Given this list of marker genes Mlh1, Chmp5, Kmt5c, Gm773, Nsmce3, Gm10230, Cenpa, Hspa2, Aurka, Tex14, Xlr4c, Mtbp, Brd7, Nifk, Macroh2a1, Tuba1a, Ccnb1-ps, Gm21865, Zwint, Syce2, Aurkc, Aurkb, Brca2, Ago3, Ccnb1, Psen1, H3f3c, Nup160, Chek1, Gm2012, Rassf2, Rnf212, Dctn2 (NCBI Gene Id 97666), Smc1b (structural maintenance of chromosomes 1B), Chmp7 (charged multivesicular body protein 7), Ahctf1, Actl6b, Nup85, Birc5, Smarcc2, Ppp1r12a, Gm21117, Gm28870, Spdl1, Cenpt, Mki67, Top2a, Dynlt3, Ncaph2, Xpo1, 1700013H16Rik, Csnk1a1, Chmp3, Cenpw, Nsmce1, Smc5, Cfdp1, Phf2, H3f5, Ttn, Hormad1, H2ax, Polb, Xlr5b, Dync1i1, Gm28102, Smc4, Phf10, Septin2, Smarcd1, Actl6a, Crebbp, Sycp2, Sycp1, Gm1140, Dync1li2, Rrs1, Pinx1, Ska2, Gm29866, Nup107, Dctn1, Kntc1, Dctn3, Cenph, Clasp1, Gm28576, Champ1, Arid2 (AT-rich interaction domain 2), Syce1, Trp53bp1, Sycp3, Smarcd2, Rad50, Sgo2b, Gm21760, Dctn5, Gm20824, Ncapd3 (NCBI Gene Id 78658), Bub1, Chmp6, Mei4, Gm5934, Septin6, Pbrm1, Sugt1, Msh5, Cebpb (NCBI Gene Id 18031), Cenpk, Chmp2a, Cenpi, Fbxo28, Lrwd1, Setmar, Cenpn, Ckap5, Rad9a, Rnf212b, Top3b, Clasp2, Zfp207, Kmt5b, Bub1b, Zw10, Cenpx, Nudcd2, Apc, Gm20890, Cdx2, Nanog, Gm29554, Ska1, Gm20911, Xlr3a, Chmp1b2, Zfp276, Chmp4c, Sec13, Meaf6, Hsf1, Fancd2, Nscme3l, Ndc80, Rad9b, Rad51, Xlr3c, Rsph1, Ska3, Cenpc1, Cenpe (centromere protein E), Gm21627, Esrrb, Cdt1 (NCBI Gene Id 97441), Lig3, Pafah1b1, Nsl1, Ttk (Ttk protein kinase), Hormad2, Syn1, Rad21 (NCBI Gene Id 19357), Nol6, Smarca4 (NCBI Gene Id 20586), Ncapg (NCBI Gene Id 70636), Psen2, Hmbs, Gm20817, Mre11a, Cenpv, Gm20820, Knstrn, Fbxw11, Trappc12, Zwilch, Sun2, Brd4, Nde1, Chmp4b, Prpf4b, Atf6b, Nup98, Actb, Banf1 (NCBI Gene Id 98145), Cenpb, Kansl1, Kif2c, Ercc6l, Spc25, Cenpf, Spag5, Dynll1, Cbx5, Kifap3, Ctcf, 4930447C04Rik, Hnrnpu, Akap8, Ppp1cc, Cdk2, Pes1, Iho1, Nup37 (NCBI Gene Id 72714), Slx, Gm20870, Plk5, 3830403N18Rik, Smc1a, Smc3, Gm10257, Atrx, Xlr4a (NCBI Gene Id 630479), Blm (NCBI Gene Id 12144), Lrpprc, Lig4, Ncapg2, Plk3, Mad1l1, Eid3, Orc2, Pmf1, Nat8, Gm2030, Tpr, Gm1993, Gm20843, Stag3, Phf6, Anapc16, Nek2, Dync1li1, Rangap1, Bub3, Msh4, Hjurp, Hmg20b, Hus1, Gm20736 (NCBI Gene Id 380994), Smarce1, Gm10488, Gm21294, Gm21996, Baz1b, Topbp1, H1f6, Meikin, Hmgb2, Dmc1, Tex12, Dctn6, Kat2b, Rad21l, Brca1, Chmp1a, Sgo1, Rad1, Gm6121, Smc2, Xlr5a, Gm28961, Mad2l1, Rif1, Cenpl, Cenpm, Spout1, Spc24, Kif18a, Bod1, Kash5, Add3, Gm21095, Smc6, Gm5168, Plk1, Firrm, Cbx3, Sgo2a, Dnmt3l, Gm14525, Nsmce4a, Gm5169, Banf2, H3f3a-ps1, Cenpo, Chmp1b, Xlr4b, Cenpp, Sycp2l, Seh1l, Gm28510, Smarca5, Fkbp6, Itgb3bp, Psmc3ip (proteasome (prosome, macropain) 26S subunit, ATPase 3, interacting protein), H3f3a-ps2, Hus1b, Tubg1, Tex11, Ndel1, Nup43, Knl1, Cenps, Kat8, Mlh3, Cenpu, Smarcb1, Rcc1, Ss18l1, Arhgap33os, Xlr3b, Sin3a, L3mbtl1, Syce1l, Gm29276, Shoc1 (shortage in chiasmata 1), H3f4, H3f3a, Gtf2b, Gm5935, Xlr5c, Hmgb1, Dsn1, Nup133, Syce3, Gm4297, Xlr, Mtcl1, Mis12 (MIS12 kinetochore complex component), Ncaph, Gm7958, Ccnb1ip1, Nsmce2, Ncapd2, Rec8, Nuf2, Septin7, Gm21858, Plk2, Smarcc1, Kif2b (NCBI Gene Id 73470), Cdc20, Dctn4, Gm6421, Cenpq, Slxl1, Gpatch11, Gm28919, Kat5, Rpa1, P3h4, Chmp2b, Incenp, here is a description of the gene set: Mouse Gene Set: GOCC_CONDENSED_CHROMOSOME A highly compacted molecule of DNA and associated proteins resulting in a cytologically distinct structure. studied in species Mus musculus